Given this list of marker genes STOX2, SPAST, CD72, TRIM9, MDGA1, CPSF2, ZNF74, PRKAB2, VTI1A, EXOC3L2, BCL6B, PEX3, SPOP, CAMK1D, NAA35, IRF6, PTPRR, AGMO, CHD3, NUMA1, MLLT6, NQO1, MED13, SIGLEC6, CCNJ, FANCD2, NCK2, AQP2, KLF10, JPH3, GRAMD1B, EPHB6, GNAS, AFAP1L1, UBE2I, CD209, ANK3, JARID2, TRIM2, CRACD, ZNF514, GPR161, MSX1, SPON1, DTX4, MTMR4, ZBTB4, BCR, CHCHD6, FGF5, PRDM15, TMEM263 (transmembrane protein 263), CLRN1, DENND4B, CARTPT, UBFD1, PHLDB1, ANKRD13C, TMCO5A, ZNF384, LUZP1, SLC25A18, TMEM198, GRIA2, BRINP1, RAB33B, SLC46A2, RSPO3, NKAPD1, TANC1, CREB3L2, ATXN1L, CCT8L2, PLEKHH2, PTCHD4, HOXA10, PKHD1, VPS36, ZNF704, MDH2, TMOD3, SLC45A3, RAB3B, IL12A, LYRM1, MYO1C, TRAF1 (NCBI Gene Id 7185), PPM1J, FBRS, DNAJB5, IFFO2, CLCN3, NDUFAF4, LAMA4, ATP7A, ZNF705A, FAM43B, CILK1, FURIN, CARF, RBM15B, FEM1B, MED21, TMEM178B, IGFBP5, CCND1, AZIN1, ADD2, NXPH1, PPP1R16B, ZNF480, VKORC1L1, TMEM135, VAX2, FRMD5, KLHL20, EPB41L1, EFNA5, RUNX2, ELF3, TPST1, ATP2C1, RNF122, KLF14, VSTM4 (NCBI Gene Id 196740), NUMB, here is a description of the gene set: Human Gene Set: MIR5088_3P from publication Chen Y, Wang X (PMID 31504780) studied in species Homo sapiens Genes predicted to be targets of miRBase v22 microRNA hsa-miR-5088-3p in miRDB v6.0 with MirTarget v4 prediction scores > 80 (high confidence targets).